Given this list of marker genes TGFB3, GLUL, ARL5A, STAM, OPTC, HIC2, KBTBD2, TVP23A (trans-golgi network vesicle protein 23 homolog A), PCDH8, CD28, FGF2, ATP4B, ITGA9, WDCP, SMIM17, DYRK1A, TOGARAM1, DLX1, ZNF131, GPR156, NEFL, GMCL1, ANXA8, FAM13A, AKR1B1, COX14, ERICH1, RUNX1T1, ZNF385B, STX6, DDX23, ANXA8L1, ARRB1, METTL9, PAK6, CLEC16A, CDR2L, PHTF2, ANKRD27, PSMB2, SNX7, ATP1B4, TOR3A, ELP1, STK40, C1orf94, PWWP2B, FAM131B, RECQL5, TBX3, PPTC7, FAIM2, NR2C2, KCNJ10, RAP1B, KCNA1, ZNF461, JADE3, HDAC2 (histone deacetylase 2), ASH1L, PPP1R14C, RNF135, PIM2, YWHAB, HS3ST3A1, ACSBG1, TMEM104, OASL, APLN, NFYB, CEP57, here is a description of the gene set: Genes predicted to be targets of miRBase v22 microRNA hsa-miR-3661 in miRDB v6.0 with MirTarget v4 prediction scores > 80 (high confidence targets). studied in species Homo sapiens from publication Chen Y, Wang X (PMID 31504780) Human Gene Set: MIR3661